The following is a description of a gene set: species: Mus musculus Genes down-regulated in a mouse model of heart disease whose expression reverted to normal by silencing of MIR21 microRNA. from publication Thum T, Gross C, Fiedler J, Fischer T, Kissler S, Bussen M, Galuppo P, Just S, Rottbauer W, Frantz S, Castoldi M, Soutschek J, Koteliansky V, Rosenwald A, Basson MA, Licht JD, Pena JT, Rouhanifard SH, Muckenthaler MU, Tuschl T, Martin GR, Bauersachs J, Engelhardt S (PMID 19043405) MicroRNAs comprise a broad class of small non-coding RNAs that control expression of complementary target messenger RNAs. Dysregulation of microRNAs by several mechanisms has been described in various disease states including cardiac disease. Whereas previous studies of cardiac disease have focused on microRNAs that are primarily expressed in cardiomyocytes, the role of microRNAs expressed in other cell types of the heart is unclear. Here we show that microRNA-21 (miR-21, also known as Mirn21) regulates the ERK-MAP kinase signalling pathway in cardiac fibroblasts, which has impacts on global cardiac structure and function. miR-21 levels are increased selectively in fibroblasts of the failing heart, augmenting ERK-MAP kinase activity through inhibition of sprouty homologue 1 (Spry1). This mechanism regulates fibroblast survival and growth factor secretion, apparently controlling the extent of interstitial fibrosis and cardiac hypertrophy. In vivo silencing of miR-21 by a specific antagomir in a mouse pressure-overload-induced disease model reduces cardiac ERK-MAP kinase activity, inhibits interstitial fibrosis and attenuates cardiac dysfunction. These findings reveal that microRNAs can contribute to myocardial disease by an effect in cardiac fibroblasts. Our results validate miR-21 as a disease target in heart failure and establish the therapeutic efficacy of microRNA therapeutic intervention in a cardiovascular disease setting. Human Gene Set: THUM_MIR21_TARGETS_HEART_DISEASE_DN, and this is the list of marker genes: ACOT1, PFKFB1, SLC7A1, ARHGAP26, NOCT, CENPF, EFEMP1, AQP4, CMSS1